Given this list of marker genes ZNF728, INSL4, SH2D5, ZNF117, CCSAP, PAPPA-AS1, GLIPR1-AS1, TCL6, SLC38A1, PLCL2, TCHHL1, TREML3P, TREML2, CRIM1, PSG2, MC1R, HSD11B2, MAN1C1, ERVE-1, CEBPB, ENSG00000256389, ST3GAL4, CRH, GDPD5, TTBK2-AS1, LINC00601, SH3TC2-DT (NCBI Gene Id 731464), ADHFE1, SLC43A2, RN7SL359P, POGLUT3, PSG8, SH3TC2, TENT5A, STS, PGF, MTMR4, LINC02291, MFSD2A (MFSD2 lysolipid transporter A, lysophospholipid), SLC16A4, HSPD1P11, HOPX, RBBP6, DYSF, PLAC1, FNDC3A, DDX59, CHODL-AS1 (NCBI Gene Id 54075), PSG6, PPP1R15B, LGALS13, CD200, HSD3B1, DVL3, IGHA1, VGLL3, SH3D21, FURIN, KATNBL1, AKR1B15, BET1-AS1, CAPN6, SDC1, MMP11, MIR4280HG, PLIN2, RRS1-DT, PP12613, SPATA9, ENSG00000261632, RYBP, GPNMB, DEPDC1B, AFF1, PHLDB2, PSG3, CSHL1, TRIM25, PCDH1, CHODL, GH2, STRA6, TCHH, LINC01483, HSD17B1, FBLN1, SEMA3B, TPRXL, SPDYA, CCK, IGSF5, ERVW-1, ZNF554, ANKRD33, C21orf91-OT1, ZSWIM2, FER1L4, NECTIN3, TINCR, GRAMD2B, EFHD1, MFSD12, LRIF1, CLIP4, GDF15, RELL2, ATG9B (autophagy related 9B), POU2F3, LGALS14, ELK1, SLC2A11, ALPP, ADM, EXPH5, PSG5, GNGT1 (NCBI Gene Id 2792), PRSS41, ENDOU, LINC01968, NAV2-AS4, LEP, CGB7, ALDH3B2, PAQR7, SEMA7A, LINC01118, BET1, LGALS16, LINC00967, RHOBTB3, LINC03016, SPTLC3, LNPEP, MIR4713HG, TRPV6, ANGPT2, PTPN21, SIN3B, C16orf74, LINC02945, TRIM40, TACC2, C4orf36, MYLIP, SLC5A6, ISM1, MAN1A2, SVEP1, LYPD5, MAFK (MAF bZIP transcription factor K), KYNU, MAGEA8, FAF1-AS1, HSPB8, PSG4, PSG9, PSG10P, ADAMTSL4, RSL1D1-DT, LY6G6C, STK3, LINC00474, GH1, OLAH, BMP1, GLDN, DAB2, MTNR1B (melatonin receptor 1B), LCMT1-AS2, ZNF703, BPGM, here is a description of the gene set: Marker genes curated from the annotated cluster as represented in the Descartes Human Gene Expression During Development database. from publication Cao J, O'Day DR, Pliner HA, Kingsley PD, Deng M, Daza RM, Zager MA, Aldinger KA, Blecher-Gonen R, Zhang F, Spielmann M, Palis J, Doherty D, Steemers FJ, Glass IA, Trapnell C, Shendure J (PMID 33184181) The gene expression program underlying the specification of human cell types is of fundamental interest. The study authors generated human cell atlases of gene expression and chromatin accessibility in fetal tissues. For gene expression, the study authors applied three-level combinatorial indexing to >110 samples representing 15 organs, ultimately profiling ~4 million single cells. The study authors leveraged the literature and other atlases to identify and annotate hundreds of cell types and subtypes, both within and across tissues. Our analyses focused on organ-specific specializations of broadly distributed cell types (such as blood, endothelial, and epithelial), sites of fetal erythropoiesis (which notably included the adrenal gland), and integration with mouse developmental atlases (such as conserved specification of blood cells). These data represent a rich resource for the exploration of in vivo human gene expression in diverse tissues and cell types. species: Homo sapiens Human Gene Set: DESCARTES_MAIN_FETAL_TROPHOBLAST_GIANT_CELLS